Given this list of marker genes Mcoln1, Tpcn2, Mcoln3, Mcoln2, Tpcn1, here is a description of the gene set: Enables the transmembrane transfer of a calcium ion by a channel that opens when nicotinic acid adenine dinucleotide phosphate (NAADP) has been bound by the channel complex or one of its constituent parts. species: Mus musculus Mouse Gene Set: GOMF_NAADP_SENSITIVE_CALCIUM_RELEASE_CHANNEL_ACTIVITY